The following is a description of a gene set: species: Homo sapiens Human Gene Set: GOMF_ADRENERGIC_RECEPTOR_ACTIVITY Combining with epinephrine or norepinephrine and transmitting the signal across the membrane by activating the alpha-subunit of an associated heterotrimeric G-protein complex., and this is the list of marker genes: GPR88, ADRB2, ADRB3, ADRB1, ADRA1D, ADRA2A, ADRA2C, ADRA1B, ADRA2B, ADRA1A